The following is a description of a gene set: Irregular menstruation Abnormally high variation in the amount of time between periods. species: Homo sapiens Human Gene Set: HP_IRREGULAR_MENSTRUATION, and this is the list of marker genes: GNAS, PHKB, CEP290, ALMS1, FOXL2, FANCM, CYP11B1, SDCCAG8, AIP, PDE4D, ARL6, TRIM32, PHKA2 (NCBI Gene Id 5256), BBS5, C14orf39, SCLT1, FMR1, PRKAR1A, MEN1, TTC8, SPATA22, BBS2 (NCBI Gene Id 583), LZTFL1, CDH23, HSF2BP, BBS7, MKKS, SOST, BBS1 (NCBI Gene Id 79702), BBS9, ERAL1, SCAPER, CFAP418, NPHP1, BBS12, BBIP1, PSMB8, CEP19, ARMC5, BBS4, CIDEC, SLC37A4, MKS1, WDPCP, ERCC8, SETD2, KDM1A, BBS10, PHKG2, IFT74 (NCBI Gene Id 80173), NR3C1, IFT172, FGFR3, CYP17A1, IFT27